The following is a description of a gene set: Type 1 IFNs can conditionally activate all of the signal transducers and activators of transcription molecules (STATs), including STAT4. The best-characterized signaling pathways use STAT1, however, and type 1 IFN inhibition of cell proliferation is STAT1 dependent. We report that type 1 IFNs can basally stimulate STAT1- and STAT4- dependent effects in CD8 T cells, but that CD8 T cells responding to infections of mice with lymphocytic choriomenigitis virus have elevated STAT4 and lower STAT1 expression with significant consequences for modifying the effects of type 1 IFN exposure. The phenotype was associated with preferential type 1 IFN activation of STAT4 as compared to STAT1. Stimulation through the TCR induced elevated STAT4 expression, and STAT4 was required for peak expansion of antigen-specific CD8 T cells, low STAT1 levels, and resistance to type 1 IFN-mediated inhibition of proliferation. Thus, a mechanism is discovered for regulating the consequences of type 1 IFN exposure in CD8 T cells, with STAT4 acting as a key molecule in driving optimal antigen-specific responses and overcoming STAT1-dependent inhibition of proliferation. Genes up-regulated in CD8 T cells with STAT4: untreated versus interferon alpha. studied in species Homo sapiens from publication Gil MP, Ploquin MJ, Watford WT, Lee SH, Kim K, Wang X, Kanno Y, O'Shea JJ, Biron CA (PMID 22968462) Human Gene Set: GSE40666_UNTREATED_VS_IFNA_STIM_STAT4_KO_EFFECTOR_CD8_TCELL_90MIN_UP, and this is the list of marker genes: VSIR, TCIRG1, ITPRIPL2, LDLR, HMOX2, HCK, EEIG1, CASP10, BAK1, VDR, C12orf75, RSU1, TFEB, SLC7A5, RUNX3, NCF2, SLCO3A1, NDST1, JPT1, DPYSL2, PRDM1 (PR/SET domain 1), PITPNC1, DAXX, OAS1, SLC16A10, APOBEC3B, NANS, HMOX1, KMT5A, GRAMD1B, RASSF2, AK8, ZBTB7A, PTPN1, TAP1, XBP1, UBE2L3, CPPED1, DNAH8, SRM, KLF8, SPATS2, BHLHE40, TNFRSF17, EBI3, MOB3A, CAMKK2, DCPS, NUGGC, MRPL4, CDC34, ZYG11A, MCM6, CENPE, HPGD, MSC (NCBI Gene Id 9242), BMF, ZYX (NCBI Gene Id 7791, zyxin), IRF5, NDC80, MAPKAPK3, SEC14L1, YPEL3, ITGA3, RHOF, SCAMP5, RASSF6, BAIAP3, IL6R, USP46, MTMR14, SH3BGRL3, LPXN, ITPK1, SND1, UBE2N, ZDHHC16, CUTA, SFXN1, UBE2G1, MT2A, GSTK1, PLEKHG7, PLIN2, HJURP, ARID5A, R3HDM4 (NCBI Gene Id 91300), MARCKS, MAP3K7CL (NCBI Gene Id 56911), CCDC24, SHMT2, EZH2, STK38L (NCBI Gene Id 23012), TRIB1, ARL3, RNFT2, LTK, SCFD1, KEAP1, YWHAH, SAMD13, PFN1, AZIN1, PTAFR, SLC1A5, KPNA2, ATOSB, AHR, SLAMF7, KCNQ5, ASPM, ACTG1, C5AR2, TFDP1, ACOT4, CCNE1, PLCG2 (NCBI Gene Id 5336), GTDC1, GPRC5D, PRR11, ARHGAP44, PSEN2, EHD1, OGDH, ZBTB32, GLMP, MGLL, BUB1, ECE1, CD226, RASGRF1, KCNA2, TAGLN2, IER2, STK38, BICRAL, DUSP2, RHOG, ARHGDIA, NLRC5, H2BC14, TRAM2, CD151, HK1, ADA2, CHAD, C16orf54, TBC1D27P, KCNH2, PLK4, HYOU1, CHN2, CAPG, S100A11, HIPK2, AGPS, SLC5A3, CAPZB, LGALSL, SUOX, TUFT1, RANBP3, ILDR1, ACP5, NCOA4, TET2, INPP4A, TRIM47, QPCTL, ANXA4, SEC24D, MYO1F, ITGAX, ADAT1, GET3, SEC61B, NAPSA, PLEKHA7, GUSB, CORO7, RASGRP1 (RAS guanyl releasing protein 1), MLKL, YKT6, ZBP1, AP2S1, VOPP1, GPRIN3, USP28, CDYL2, CMTM7, TIAM2, ARF1, ITGAM, SLC43A3, CYFIP1, LILRB4, ADTRP, SDF4, PI4K2A, TRERF1